The following is a description of a gene set: Mouse Gene Set: GOMF_NITRIC_OXIDE_SYNTHASE_REGULATOR_ACTIVITY Binds to and modulates the activity of nitric oxide synthase. studied in species Mus musculus, and this is the list of marker genes: Calm1, Hsp90aa1, Atp2b4, Hsp90ab1, Akt1, Dynll1, Calm2, Calm3